The following is a description of a gene set: studied in species Homo sapiens Human Gene Set: KEGG_MEDICUS_REFERENCE_DISASSEMBLY_OF_MCC Pathway Definition from KEGG: TRIP13+MAD2L1BP -| MCC -| ANAPC Disassembly of MCC. Pathway ID: N01533. Pathway type: Reference. Pathway class: nt06515 Regulation of kinetochore-microtubule interactions., and this is the list of marker genes: ANAPC11, ANAPC5 (anaphase promoting complex subunit 5), ANAPC2, BUB1B, MAD2L1BP, ANAPC1, CDC20, TRIP13, ANAPC4, CDC27, ANAPC7, BUB3, CDC26, CDC16, CDC23, ANAPC10, MAD2L1